Given this list of marker genes GLYATL3, HSF2BP, OVOL1, MINDY2, IFIT2, HS3ST3A1, HNRNPR, SGMS1, LHFPL5, ACTR3 (actin related protein 3), PCNA, SLC46A2, DOCK1, GATM, LIN9, VPS4B, GALNT7, ZHX2, RNF19A, PCDH15, LYVE1, CNGA2, LTBP1, CISD3, ADCY5, TOR1B, HDHD2, CDKN2AIP, PTPRJ, TMEM237, CEP164, MYZAP, NPTN, PCGF5, DMGDH, CUL2, CBS, CDH20, DCAF6, ANGPTL2, PLAGL2, SULT1E1, CFAP97, TADA1, ADAM18, VSIG1, SOS2, TET3, SLC6A11, FZD3, CAMK4, NOS3, MAP4, E2F5, MYLK, ZMYM1, VPS53, TMEM108, AQP9, AGMO, ENSG00000274276, DISC1, GABRR1, ZCCHC7, CAPN6, TMX1, PIWIL1, here is a description of the gene set: Human Gene Set: MIR154_5P Genes predicted to be targets of miRBase v22 microRNA hsa-miR-154-5p in miRDB v6.0 with MirTarget v4 prediction scores > 80 (high confidence targets). from publication Chen Y, Wang X (PMID 31504780) studied in species Homo sapiens